Given this list of marker genes CHST14, DOK7, SLC18A3, DSE, MYH3, KIF21A, TUBA1A, MAGEL2, PLOD3, RAPSN, PIEZO2, SLC39A13, MUSK, AUTS2, RIPK4, NUP88, NALCN, MYOD1, here is a description of the gene set: Human Gene Set: HP_APLASIA_HYPOPLASIA_OF_THE_PALMAR_CREASES studied in species Homo sapiens Aplasia/Hypoplasia of the palmar creases Absence or underdevelopment of the palmar creases.